Given this list of marker genes ADCYAP1, GNRH1, UCN2 (urocortin 2), FYN, UCN3, VIP, CCK, PTHLH, PTPN11, GHRH, JAK2, PTH, GNAO1, PSMC5, UCN, CRH, GPHA2, LEP, GNRH2, GPHB5, GRIA1, GNAS, here is a description of the gene set: Human Gene Set: GOMF_PEPTIDE_HORMONE_RECEPTOR_BINDING species: Homo sapiens Binding to a receptor for a peptide hormone.